The following is a description of a gene set: Human Gene Set: DESCARTES_MAIN_FETAL_ELF3_AGBL2_POSITIVE_CELLS from publication Cao J, O'Day DR, Pliner HA, Kingsley PD, Deng M, Daza RM, Zager MA, Aldinger KA, Blecher-Gonen R, Zhang F, Spielmann M, Palis J, Doherty D, Steemers FJ, Glass IA, Trapnell C, Shendure J (PMID 33184181) The gene expression program underlying the specification of human cell types is of fundamental interest. The study authors generated human cell atlases of gene expression and chromatin accessibility in fetal tissues. For gene expression, the study authors applied three-level combinatorial indexing to >110 samples representing 15 organs, ultimately profiling ~4 million single cells. The study authors leveraged the literature and other atlases to identify and annotate hundreds of cell types and subtypes, both within and across tissues. Our analyses focused on organ-specific specializations of broadly distributed cell types (such as blood, endothelial, and epithelial), sites of fetal erythropoiesis (which notably included the adrenal gland), and integration with mouse developmental atlases (such as conserved specification of blood cells). These data represent a rich resource for the exploration of in vivo human gene expression in diverse tissues and cell types. Marker genes curated from the annotated cluster as represented in the Descartes Human Gene Expression During Development database. studied in species Homo sapiens, and this is the list of marker genes: RNU6-94P, COL11A2, ARHGAP5-AS1, DCXR, ILRUN-AS1, LINC00853, RNU6-228P, SRP9, AKTIP, RPL37P23, MISFA, RPS15AP38, OPLAH, FAM180A, PFDN1, BCKDK, HDHD5, ULK3, TAF9B, MRPS11, ITFG2-AS1, PAPLN-AS1, TIPARP-AS1, ZNF319, LINC02299, FTH1P16, RRP8, LINC02455, RMND5A, POMGNT1, CCZ1, CRTC2, RNU6-125P, ISCA2, UQCRFS1, RNU6-1251P, COA7, CPHL1P, DCAF8L2, LINC01801 (NCBI Gene Id 400685), PTTG1, LINC00881, BNIP3, MRAS, DOK7, THAP2, LCDR, TMEM242, SLC2A4, ZFP57, C4orf51, ENSG00000261335, RBIS, ECHDC3, HMGB1P39, STUB1, ENSG00000231119, MTHFSD, LINC01560, CRAT, B3GALNT1, EIF2S3B, TPT1P4, PTP4A3, METTL23, TINF2 (NCBI Gene Id 26277), LINC00400, FGF14-AS2, ATP5MJ, ZNF580, FAM86EP, NUDT22, PFKP-DT, LINC02832, TMEM126B, NUP37, PSMG1, ATP5MF-PTCD1, PRSS46P, TMEM230, PPP1R3B, C15orf61, RPS15AP11, RXYLT1-AS1, MPC1, ZNF419 (NCBI Gene Id 79744), RPL26P19, LINC02660, MRPL37, IL20RA, ARHGEF39, BBS10, PPP1R26, TIMM10, AKAP5, TAF6, SNF8, ZNF792, SYNM-AS1, MZT1 (NCBI Gene Id 440145), SDR9C7 (short chain dehydrogenase/reductase family 9C member 7), DMTF1-AS1, MRPL10, RPL39L, ASB10, ZNF691, LINC02208, NCBP2AS2, GAS6-DT, CSNK2A2 (casein kinase 2 alpha 2, NCBI Gene Id 650690), CDK18, DDA1, KCNJ2-AS1, ZNF639, GOLIM4, TUBG1, GFOD3P, ZNF770, TP53INP2, HNRNPH3, LINC01936, NFILZ, LINC01405, FUNDC2, TRIM69, AATBC, AGPAT1 (NCBI Gene Id 84827), RPL10P9, ASIC4-AS1, NUDT8, COPS5, MPV17L2, SCAMP1-AS1 (NCBI Gene Id 730815), ALKBH6, LYSMD4, SCN1B, MTCH1, IDH3A, GDE1, ZNF436-AS1, LINC01191, RNF113A, RBM14, RBM18, NUDT10, TBC1D8-AS1, MRPL15, ERCC4, H3C12, ANKRD2, TRIM41, KLC1-AS1, SMIM27, ZNF451-AS1, LSM1, ACAD8, NPY6R, PGAM2, STAG2-AS1, SNHG18, SMCO1, SLC35A4, CACNA1C-IT3, SORBS2-AS1, ZNF524, ACTR8, SRRM5, TRIM68, HIPK1-AS1 (NCBI Gene Id 101928846), ZNF654 (zinc finger protein 654), NARF-AS2, BRK1, CDC40, BANF1, LINC02713, DUSP28 (dual specificity phosphatase 28), IER5L-AS1, SH3GL1P1, TRMT10C, ZNF134, COX5A, MOCS3, ST13P15, CDCA4, PHPT1, SAAL1, EIF5AL1, GTF2IP5, PYGB, SMIM30, MCRS1, TMEM50B, VMA21, JDP2-AS1, PSMB2, RRAD, HYLS1, ZNF32-AS1, LRRK2-DT, COX6A2, LOXL2-AS1, GSPT1, AMER1, ANO7, CNN1, ENSG00000272970 (novel transcript), LCMT2, CCT8 (NCBI Gene Id 9888), ZNF28, PRMT5-AS1, TOMM22, YBX2, ANKRD20A18P (NCBI Gene Id 391269), FIZ1, CDK16, GJB4